Given this list of marker genes ECRG4, POMC, TAC1, TSPO, CRHR1, CRH, here is a description of the gene set: Any process that modulates the frequency, rate or extent of corticosterone secretion. studied in species Homo sapiens Human Gene Set: GOBP_REGULATION_OF_CORTICOSTERONE_SECRETION